Given this list of marker genes CCDC12, MAP1LC3B, NAPSA, FOXO1, BCAS3, NIPAL3, ZFTRAF1, ARRDC3, PKIB, HSD3B7, TPRG1L, DNAAF4, PRKCB, MSI2, NOD1, SLC25A53 (NCBI Gene Id 401612), CDIPT, ZNF394, ZYX, GIMAP4, CD247, OCSTAMP, DLGAP4, INPP5B, NCF1, TRIM14, PDRG1 (p53 and DNA damage regulated 1), CCM2, MGST2, RINL, TMCO4, TAPBP, CC2D1A, RABEP2, GPR35, PCMTD2, ACOXL, MFAP3, LPP-AS2, BICDL1, GPR4, GALT, CD84, PAK1, EOLA1, CNR2, NDUFB11, IL6R, IFI35, NRIP1, GBP2, TXNDC12, PPIB, ELOA, SDF4, DTX2, CCDC93, TAF10, ZFYVE1, YPEL5, C19orf38, BCL9L, GRAMD1B, GIMAP8, LAPTM4B, RUNDC1, TRIO, F2R, FMNL2, CARNS1, PRKRA, TM6SF1, TLR1, RGS2, ARHGEF4, SSH1, GRAMD2B, IL1RL1, FOS, FAM50A, DNMBP, IKBKE, TXLNG, CA2, MED15, OTUD1, WDR81, AR, VAMP5, TRPM1, NCKAP5L, CYB561A3, SVBP, SCYL3, GRK6, MREG, CYRIA, MBNL2, CCND1, SLA2, ZFYVE27, CHFR, AP5Z1, ZNF524, ISG20, SDC3, EIF2B2, FOXO4 (NCBI Gene Id 4303), PEAK1, FAM32A, RNPEPL1, FBXW4, STIM2, ACSS1, ATOSA, TRIM39, EMB, CYBC1, PLEKHG2, COG2, LY86, SMIM8, ZNF790, IL4R, EAPP, RFLNB (refilin B), KATNB1, PKD1, UNC119B, SAYSD1 (SAYSVFN motif domain containing 1), HSD17B8, SORL1, ASXL2, PARP8 (poly(ADP-ribose) polymerase family member 8), CIZ1, CRLF2, CLCN7, ZBTB18, CORO7, TBRG1, MINDY2, FBXL12, CPNE3, UPF3A, ST3GAL6, GPR171, SUGT1, P2RX4, UBALD2, DTX3L, UQCC3, NR4A1, MARCHF1, CERK, BAG1 (BAG cochaperone 1), IFT140, ACTN2, NFKBIE, PLCL2, TXNDC15, DCXR, TAF1C, ZNF579, KIT (KIT proto-oncogene, receptor tyrosine kinase), ERMP1, EPS8L1, CRIM1, AAMDC, ABTB3, TNFSF14, RERE, TBC1D8, LAG3, PEA15, LY6E, WSB2, IFNGR1, MEF2D, WDR45, METTL27, FILIP1L, KLF13, SATB1, GMIP, RASSF4, ZNRF1, COQ8A, TMEM230, PHF21A, CUX1, MARK3 (NCBI Gene Id 4140), CCDC126, CASP4, IAH1, PHYH, KDM5B, FMO5, PRKCH, SUSD1, CABLES1, here is a description of the gene set: Human Gene Set: GSE19825_IL2RALOW_VS_IL2RAHIGH_DAY3_EFF_CD8_TCELL_UP Genes up-regulated in comparison of effector CD8 IL2RA low T cells versus effector CD8 IL2RA high cells. CD25, the high affinity interleukin-2 (IL-2) receptor alpha-chain, is rapidly upregulated by antigen-specific CD8+ T cells after T cell receptor stimulation. We demonstrated that during an acute viral infection, CD25 expression was dynamic, and a subset of virus-specific CD8+ T cells sustained CD25 expression longer than the rest. Examination of the in vivo fate of effector CD8+ T cells exhibiting differential responsiveness to IL-2 revealed that CD25lo cells, which were relatively less sensitive to IL-2, preferentially upregulated CD127 and CD62L and gave rise to the functional long-lived memory pool. In contrast, CD25hi cells that accumulate enhanced IL-2 signals, proliferated more rapidly, were prone to apoptosis, exhibited a more pronounced effector phenotype, and appeared to be terminally differentiated. Sustained IL-2 receptor signaling resulted in increased CD8+ T cell proliferation, higher granzyme B expression and exaggerated contraction after antigen clearance. These data support the hypothesis that prolonged IL-2 signals during priming promote terminal effector differentiation of CD8+ T cells. from publication Kalia V, Sarkar S, Subramaniam S, Haining WN, Smith KA, Ahmed R (PMID 20096608) studied in species Homo sapiens